Given this list of marker genes Slc2a1, Spint1, Gramd4, Slfn2 (schlafen 2), Relb, Coro2a, Psme2, Tmed5, Rbm3, Nampt, Slamf8, Il4ra, Slc30a4, Ly86, Cd209d, Cltc, Spi1, Bak1, Sf3b6, Syngr2, Srsf3, Prkcd, Tspan13, Nup98, Tle3, Rab3il1, Slc15a3, G3bp1, Ppp1r11, Tnip3, Wdr43, Rnf19b, Calr, Nfkb1, Tbc1d16, Arl8b, Tuba4a, Ubfd1, Cd24a, Naa15, Myd88, Kynu, Cd209a, Lyn, Sting1, Bcl2a1d, Ywhae, Il4i1, Cyp4f16, Bcl3, Ppa1, Socs1, Psmb9, Ppp1r2, Olfm1, Psmb8, Lsm4, Ass1, Ncl, Trim30a, Prps1, Stx11, Dtx3l, Lcp1, Irgm2, Myo1e, H2-T23, Tap2, Ccdc86, Adam23, Tmed7, Lrrk1, Mgl2, Efhd2 (NCBI Gene Id 99974), Fyn, Lsg1, Ece1, Pdia3, Litaf, Gar1, S100a6, Atp5mc1, Stat3, Srsf9, Zyx, Ikzf1, Kdm6b, Naaa, Picalm, Kars1, Eef1e1, Cdkn1a, Gbp2, Cflar, Arap2, Pfkp, Batf3, Gbp5, Gbp7, Sbno2, Cdc34, Serpina3g, Gfra2, Igtp, Tmem106a, Denr, Tnfrsf1a, Hspa5, Kif1a, Pnp, Sel1l, Eif1, Clec10a, Cxcl10, Gtpbp4, Arid5a (AT-rich interaction domain 5A), Plekho2, Rin3, Exosc3, Cxcl9, Rap1a, Wdr1, Hnrnph2, Csf2rb2, Ranbp1, Srsf2, Bzw2 (NCBI Gene Id 66912), Il21r, Ccl17 (NCBI Gene Id 20295), Clic4, Xbp1, Apobec3, Rrp9 (ribosomal RNA processing 9, U3 small nucleolar RNA binding protein), Parp9, Cycs, Ly6a, Ifi35, Plek, Tap1, Pim1 (proviral integration site 1), Zfand3, Sar1a, Ifi47, Psma2, Serpina3f, Ssr2 (signal sequence receptor, beta), Pak2, Ptpn1, Llph, Ccr5, Orai1, Dnajc2, Cish, Smdt1, Actr3, Marcksl1, Gatm, Parp14, Psenen, Pdcd1lg2, S100a4, Eif4g2, Sdc4, Hip1, Tmem131, Eif3a, Casp6 (NCBI Gene Id 12368), Snap23, Ak2, Lsm12, Fnbp1l, Dimt1, Cd274, Ciita, Slc39a1, Ppig, Vrk1, Noc4l, Ywhaz, Icam1, Malt1, Eif4e, Hspa8, Naa25, Dynll1, Cyrib, Kmo, Gpr171, Vasp, Psma3 (NCBI Gene Id 19167), Nr4a3, Bysl, Srgn, F2rl2, Gprc5c, Cacybp, Samhd1 (NCBI Gene Id 56045), Tspo, Nop58, Ostc, Actr2, Etv3, Gbp9, Cst7, Ssb, B4galt3, Irgm1, Ddx39a, Adam8, Selenos, Fcgrt, Cyp7b1, Tuba1b, Slfn5, Bex6 (brain expressed family member 6), Syncrip (NCBI Gene Id 78260), Myl12a, Ifi207, Stat1, Scimp, Lrrc59, Dnajb11, Arhgap31, Iqgap1, Cd209e, Cd40, Ctsz, Cdh1, Htr7, Pik3cd, Gbp4, Ngfr, Gnl3, Psma7, Nrp2, Ost4, Cd53, Stat5a, Eif4a1, Napsa, Snrpd1, Snu13, Traf1, Jak2, Zfp800, Bzw1, Hnrnpk, Snx3, Vim, Eps8, Dnajc3, Uck2, Rbm8a, Nlrc5 (NLR family, CARD domain containing 5), Ms4a6d, Septin3, Phc2, Mybbp1a, Tpm3, Wdfy4, Irf5, Iigp1 (NCBI Gene Id 73042), Kdr, Runx1, Mtdh, Cct8, Creld2, Ms4a4c, Eif5a (NCBI Gene Id 28059), Cst3, Manf, Srsf7, Clec4n, Ifi203, Nme1, Cd300a, Mettl1, Bcl2a1b, Zfp366, Socs2, Fabp5, Zbp1, Aqp3, Eif2ak2, Mat2a, Basp1, Timm17a, Socs3, Arhgdia, AA467197, Pfn1, Dok2, Atp2c1, Tapbpl, Tagln2, Tmem128, Irf1, Oasl2, Pdia6, Hsp90b1, Ptges3, Tarm1, Smarca5, Ruvbl1, here is a description of the gene set: Genes positively differentially expressed in cell type: cDC2 (conventional dendritic cell type 2) upon treatment with cytokine: IL-2 in mouse lymph nodes in vivo. Mouse Gene Set: CUI_CDC2_IL2_RESPONSE_UP species: Mus musculus Cytokines mediate cell-cell communication in the immune system and represent important therapeutic targets. A myriad of studies have highlighted their central role in immune function, yet we lack a global view of the cellular responses of each immune cell type to each cytokine. To address this gap, the authors created the Immune Dictionary, a compendium of single-cell transcriptomic profiles of more than 17 immune cell types in response to each of 86 cytokines (>1,400 cytokine-cell type combinations) in mouse lymph nodes in vivo. A cytokine-centric view of the dictionary revealed that most cytokines induce highly cell-type-specific responses. For example, the inflammatory cytokine interleukin-1β induces distinct gene programmes in almost every cell type. A cell-type-centric view of the dictionary identified more than 66 cytokine-driven cellular polarization states across immune cell types, including previously uncharacterized states such as an interleukin-18-induced polyfunctional natural killer cell state. from publication Cui A, Huang T, Li S, Ma A, Pérez JL, Sander C, Keskin DB, Wu CJ, Fraenkel E, Hacohen N (PMID 38057668)